The following is a description of a gene set: studied in species Homo sapiens from publication Yevshin I, Sharipov R, Kolmykov S, Kondrakhin Y, Kolpakov F (PMID 30445619) Human Gene Set: ZNF133_TARGET_GENES Genes containing one or more binding sites for (ZNF133) in their promoter regions (TSS -1000,+100 bp) as identified by GTRD version 20.06 ChIP-seq harmonization., and this is the list of marker genes: MYO5C, TRIM25, LIG1, KLHL32, TM7SF3, PHYHIP, NUP35, ZNF799 (NCBI Gene Id 90576), AXL, KRT8, PCDHA2, REV1, PLCXD1, TBC1D12, EXOSC8, BPHL, RTN4R, CTNNBL1, AKTIP, TCF12, CBFA2T3, TSFM, NR2F1-AS1, CYP17A1, RPS4XP20, ZSWIM9, ACY1 (NCBI Gene Id 95), SERPINE1, ATP6V1G1P6, ARHGEF5, KLHDC9, C14orf119P1, LCA5, KRT18, HUNK, TMEM248, PPARG, SOX8, ZNF3, TXLNB, ACAD11, NGLY1, MX2, DYNLT1, FCHSD2, KCNQ4, ZNF827, ZNF423, ZNF566, DNAJB1, OTUD4, CEROX1, NPAS3, SLC2A11, PROCA1, ORMDL2, C1orf159, RNU6-810P, RN7SL567P, LINC00824, DDX52, TSC1, PRKCSH, HSDL2-AS1, MIR9-2HG, RGSL1, CBX1P3, NOVA1, DCANP1, TRIM55, FABP5P9, ENSG00000270240, LINC02987, ELAC2, QKI, WDR25, ZNF790-AS1, LIFR, GBA1, ENSG00000221060, SMCO4, STAT6, NTRK3, EML1, TRIM16L, ADAMTS9, C1R, ASAH1 (N-acylsphingosine amidohydrolase 1), CHCHD4P4, NOVA1-DT (NCBI Gene Id 387977), FGD5, HNRNPCP4, SNORD17, SEMA3B, TTC3, SYT17 (synaptotagmin 17), SPATS2L, PPP2R5C, OR10A5, HEXD, PCBP1-AS1, TUBBP5, RPS27AP7, FAM168A, ISCA1, SRP54-AS1, CYP4X1, SRP54, MEF2C, SUCO, ATOSA, KIAA1958, AATK, AAGAB, RBMS3, TTC19, PDK3, SNX5, CCN1, HSD11B1-AS1, HNF4G, KRT2, RHOQ-AS1, LARP1, ZNF260, G0S2, FGL1, MCM8-AS1, SPMIP5, SLC30A6, IL6R, CERKL, JAGN1, CHD5, MESTP2, N4BP2L2, PPP1CC, IQCH, EEFSEC, THOC1, EFCAB7, LINC03109, ZNF404, RAB4A, ENSG00000258168, RNU6-1322P, EXTL3, ZNF45-AS1, ALG5, METTL13, NLRC5, MYH11, C2orf74, SH2D5, CFAP251, SEC16B, HLA-DMA, MLST8, IPO5P1, DNMT3B, RBBP5, TRIM16, MRPL1, AP1AR-DT, TNPO1, SLC12A4, ITGA7, SLC25A37, NRXN1, SFXN1, RHOQ, RPSAP38 (ribosomal protein SA pseudogene 38), POLG, HIF3A, TYK2, RAB4A-AS1, GABRB3, ANKRD13C, TSHZ2, CRLS1, LRRC59, BCL2L1-AS1, DALRD3, RAB3C, SLC22A11, ENSG00000267058, ITGB3BP, AGO1, SLC35B4, LINC00662, TTLL7-IT1, MAGED2, PHF20, PTPRM, PSMD4, TM2D3, ZNF808, CCT6P3 (NCBI Gene Id 649553), STX17, KIAA0513, TBPL1, HCG27, PTP4A2, SMG7, GPRC5B, SIKE1, ADAM9, SCIN, COQ9, RNY1P6 (NCBI Gene Id 100873805), VPS4B, POU2F2, DPPA2P4, RNU6-740P, BCL2L11, RNF150, SBF2, RN7SL382P, LMF1, ZNF132, AP1AR, TOP3B, CCDC18-AS1, CCDC144BP, EXD3, IFFO2, SLC16A1, ZNF521, ASNS, ALCAM, PARN, LINC02884 (long intergenic non-protein coding RNA 2884), IREB2, MACF1, VGLL4, KCNJ2, SNHG14, RPL6P28, GTF3C6P3